Given this list of marker genes CCNF, NPRL3, HBA2, SNX22, E2F4, VRK1, H1-5, STIL, CISD2, H4C3, HBZP1, DENND4A, HK1, SLC25A21, EPB42, WNK1, RNF224, CENPL (NCBI Gene Id 91687), HBZ, HMMR, TBC1D22B, EZH1, FAM117A, SPTB, MIGA2, HBB, HJURP, SPECC1 (sperm antigen with calponin homology and coiled-coil domains 1), RHCE, SPAG5, KIAA1586, NUSAP1, SPMAP2L, TSPAN5, CDC27, KLF1, STAM, PRC1, C17orf99, MBOAT2, DCAF12, TANGO2, ZNF367, NRIR, SLC22A16, USP32, RFESD, VCF1, BNIP3L, KCTD9P1, ABCB10, ABCB6, STEAP3, MRPS9, CAT, MOSPD1, BSG, AMMECR1, USP15, UGGT1, UBAC1, C2CD3, SLC4A1, SMILR (smooth muscle induced lncRNA, enhancer of proliferation), FBXO7, MACO1, NCAPG, ZNF451, GYPC, ALAS2, SLC5A4-AS1, HMGN1P8, TFRC, FAXDC2, HBQ1, ACSBG1, ALAD, HAUS2, IBA57, SEC22C, CMPK2, RRM2, RN7SKP124, CENPI, RAPGEF2, GMPR, SCYL2P1, HTRA2 (NCBI Gene Id 27429), FAM83D, KEL, TRIM10, MORC3, EIF5AP2, WRN (WRN RecQ like helicase), HEMGN, RCCD1, DLGAP5, CA1 (carbonic anhydrase 1), POLH-AS1, AKAP8L, PHOSPHO1, CPOX, BLVRB, ESPL1, MARCHF3, H2AC16, EPOR, NCEH1, EP300, ENSG00000189316, SNCA, FCHO2, FAM178B, NAPEPLD, ATAD5, LINC02772, ERMAP, C9orf85P2, HBG1 (NCBI Gene Id 8047), GCLC, KMT5A, BGLT3, MARK3, CHTF18, ANK1, DHRS13, E2F2, ENSG00000260592, TRAK2, ART4, LINC02444, MINPP1, IFIT1B, RNF123, SEC14L4, KIF22, CENPE, RCL1, EXO1, ATG14, YPEL4, TMCC2, TCEANC, KIF4A, RECQL4, SPTA1, BTNL10P, AHSP, XPO7, NARF, MARCHF8, CD58, RMDN3, SNORD13E, GLRX5 (NCBI Gene Id 51218), RSAD2, CAMKMT, PRR5, ZSCAN5A-AS1 (NCBI Gene Id 112268243), KIF18B, DBF4, CR1L, GYPA, SLC6A9, TOP1, KIF23 (NCBI Gene Id 981), TSPAN5-DT, HBG2, GAPVD1, HBA1, LARP1, EIF2AK1, PPME1, PKLR, RSRC1, ABCB5, ST3GAL2, SELENBP1, ARRDC2, MOB1B, ORC1, HBM, DDI2, RN7SL724P, MAP2K3, ANKLE1, CDC20 (NCBI Gene Id 991), AURKA, LINC01399, HBE1, QSOX2, ANP32B, LPCAT3, DYRK3, FBXO9, PIGC, LINC02506, PIGQ, DNAJC6, FECH, DCUN1D1, DMTN (dematin actin binding protein), HMBS, SLC14A1, CD46P1, ANKRD9, HBBP1, RBM38, SEC62, SLC43A3 (NCBI Gene Id 55543), UROS, UROD, AP2A1, TRIM58, SLC25A37, TBCEL, DCAF11, GYPE, CBLL1, TLCD4, RHAG, CROCCP2, TFR2, HECTD4, ANKRD18B, SLC25A39, ACSL6, XK, ATG4A, ABCC13, TMEM14B, SLC11A2, RGS6, TROAP, TMEM120B, TCP11L2, PARPBP, PRDX2, C9orf40, RHD, TFDP1, ABCA7, RNU6-370P, TSPO2, GYPB, here is a description of the gene set: The gene expression program underlying the specification of human cell types is of fundamental interest. The study authors generated human cell atlases of gene expression and chromatin accessibility in fetal tissues. For gene expression, the study authors applied three-level combinatorial indexing to >110 samples representing 15 organs, ultimately profiling ~4 million single cells. The study authors leveraged the literature and other atlases to identify and annotate hundreds of cell types and subtypes, both within and across tissues. Our analyses focused on organ-specific specializations of broadly distributed cell types (such as blood, endothelial, and epithelial), sites of fetal erythropoiesis (which notably included the adrenal gland), and integration with mouse developmental atlases (such as conserved specification of blood cells). These data represent a rich resource for the exploration of in vivo human gene expression in diverse tissues and cell types. Human Gene Set: DESCARTES_MAIN_FETAL_ERYTHROBLASTS Marker genes curated from the annotated cluster as represented in the Descartes Human Gene Expression During Development database. species: Homo sapiens from publication Cao J, O'Day DR, Pliner HA, Kingsley PD, Deng M, Daza RM, Zager MA, Aldinger KA, Blecher-Gonen R, Zhang F, Spielmann M, Palis J, Doherty D, Steemers FJ, Glass IA, Trapnell C, Shendure J (PMID 33184181)